The following is a description of a gene set: The process of regulating the proliferation and elimination of mast cells such that the total number of mast cells within a whole or part of an organism is stable over time in the absence of an outside stimulus. species: Homo sapiens Human Gene Set: GOBP_MAST_CELL_HOMEOSTASIS, and this is the list of marker genes: ADAM17, NF1, STAT5A, KITLG, FCER1G, SLC15A4